Given this list of marker genes DOCK5, CFAP90, TKTL1, NAXD, RNF149, here is a description of the gene set: Genes predicted to be targets of miRBase v22 microRNA hsa-miR-3186-5p in miRDB v6.0 with MirTarget v4 prediction scores > 80 (high confidence targets). from publication Chen Y, Wang X (PMID 31504780) Human Gene Set: MIR3186_5P studied in species Homo sapiens